The following is a description of a gene set: The process whose specific outcome is the progression of the pallium over time, from its formation to the mature structure. The pallium is the roof region of the telencephalon. studied in species Homo sapiens Human Gene Set: GOBP_PALLIUM_DEVELOPMENT, and this is the list of marker genes: FBXO45, PTEN, SLC38A2, HTR5A, LMX1A, EZH1, TSC1, SUN2, PAX6, FEZF2, SRD5A2, PAFAH1B1, PEX13, XRN2, TUBA1A, DAB2IP, CDK5R2, BMERB1, SRF, ZEB2, NKX2-1, DLX1, PEX5, FOXG1, SRGAP2C (SLIT-ROBO Rho GTPase activating protein 2C), CDK5R1, KDM6B, NSUN5, SCT, CCDC39, NF1, POU3F2, NOTCH2NLA, ROBO1, LHX6, BLOC1S6, ZIC3, LEF1, PPP1R9B, SLC2A1, DAB1, ID4, PLXNA3, NEUROD6, CFL1, NOTCH2NLB, TBR1, CTNNB1, SUN1, GSK3B, ZMIZ1, ATIC, LHX5 (NCBI Gene Id 64211), LAMB1, NDEL1, WNT3A, BBS4, TRAPPC9 (NCBI Gene Id 83696), LHX2, COL3A1, HDAC1, CRKL, LARGE1, FGF13, CDK6, DIXDC1, CCDC85C, BCAN, DISC1, KIRREL3, PALS1 (protein associated with LIN7 1, MAGUK p55 family member), CNTNAP2, FOS, NOTCH2NLC, CDH2, TMEM108, FBXO41, CDK5, SEMA6B, CCDC141, EOMES, PTPRS, TMEM14B, BBS2, PSEN1, NARS1, NTRK2, NF2 (NF2, moesin-ezrin-radixin like (MERLIN) tumor suppressor), POMGNT1 (NCBI Gene Id 55624), RAC1, CEP120, EPHA5, EMX1, BAX, EIF2B5, SYNE2, FKTN, MGARP, TP73, ALK, YWHAE, RELN, TRA2B, FEZ1, FXR1, TACC1, ADGRG1, ATAT1, TFAP2C, PAX5, RAN, KDM1A, TACC2, KIF26A, DMRTA2, FXR2, XRCC1, EGFR, TUBB2B, KIF14, NR4A3, MBOAT7, MDGA1 (MAM domain containing glycosylphosphatidylinositol anchor 1), P2RY12, PIANP, BBS1, NCOA1, NR2E1, NEUROD1, SLC32A1, ASPM, HTR6, FAT4, PROX1, POMT2, BTBD3, DCLK2, UQCRQ, SRD5A1, CSNK2A2, KCNA1, MCPH1, SLIT2, RARA, CDON, DLX2, NPY, LRP8, VPS13B, EZH2, SOCS7, HIF1A, ASCL1, ATG16L1, FOXP2, BNIP3, CRK, TSKU, POU3F3, FUT10, RTN4, TUBB2A, KCNA2, MKKS, XAB2, ATP2B4, FGF8, AKIRIN2, TACC3 (transforming acidic coiled-coil containing protein 3), OGDH, PHACTR1, ATOH1, BTG2, CASP3, NDE1, IGF2BP1, WDR62, ZIC1, PHLPP2, ARX, DRD1, NEFL, MDK, ARHGAP11B, EFHC1, GRIA1, GLI3, MFSD2A, EMX2, FLNA, SRGAP2, GART, WDR47 (WD repeat domain 47), PLCB1, RHOA, FILIP1, SMO (NCBI Gene Id 6608)